The following is a description of a gene set: Any process that stops, prevents, or reduces the frequency, rate or extent of the controlled release of glutamate. species: Mus musculus Mouse Gene Set: GOBP_NEGATIVE_REGULATION_OF_GLUTAMATE_SECRETION, and this is the list of marker genes: Trh, Htr6, Adora1 (adenosine A1 receptor), Il1b, Npy5r, Hrh3, Prkg1, Il1rn, Grm7